The following is a description of a gene set: studied in species Mus musculus Naturally arising CD25+CD4+ regulatory T cells (T(R) cells) are engaged in the maintenance of immunological self-tolerance and immune homeostasis by suppressing aberrant or excessive immune responses, such as autoimmune disease and allergy. T(R) cells specifically express the transcription factor Foxp3, a key regulator of T(R)-cell development and function. Ectopic expression of Foxp3 in conventional T cells is indeed sufficient to confer suppressive activity, repress the production of cytokines such as interleukin-2 (IL-2) and interferon-gamma (IFN-gamma), and upregulate T(R)-cell-associated molecules such as CD25, cytotoxic T-lymphocyte-associated antigen-4, and glucocorticoid-induced TNF-receptor-family-related protein. However, the method by which Foxp3 controls these molecular events has yet to be explained. Here we show that the transcription factor AML1 (acute myeloid leukaemia 1)/Runx1 (Runt-related transcription factor 1), which is crucially required for normal haematopoiesis including thymic T-cell development, activates IL-2 and IFN-gamma gene expression in conventional CD4+ T cells through binding to their respective promoters. In natural T(R) cells, Foxp3 interacts physically with AML1. Several lines of evidence support a model in which the interaction suppresses IL-2 and IFN-gamma production, upregulates T(R)-cell-associated molecules, and exerts suppressive activity. This transcriptional control of T(R)-cell function by an interaction between Foxp3 and AML1 can be exploited to control physiological and pathological T-cell-mediated immune responses. Human Gene Set: ONO_AML1_TARGETS_UP Genes up-regulated in CD4+ T lymphocytes by expression of AML1 off a viral vector. from publication Ono M, Yaguchi H, Ohkura N, Kitabayashi I, Nagamura Y, Nomura T, Miyachi Y, Tsukada T, Sakaguchi S (PMID 17377532), and this is the list of marker genes: E2F1, IFNG, FOS, DLK1, CXCR6, HAVCR2, CCNF, GZMA, P2RY14, PAK1, DDX5, FASLG, MECP2, PDCD1, SEMA4A, PDCD1LG2 (NCBI Gene Id 80380), GADD45B, CD244, EOMES, RGS2, GZMB, SLAMF7, JUN, NKG7